The following is a description of a gene set: Any process that modulates the frequency, rate or extent of polyamine transmembrane transport. Mouse Gene Set: GOBP_REGULATION_OF_POLYAMINE_TRANSMEMBRANE_TRANSPORT species: Mus musculus, and this is the list of marker genes: Oaz3, Oaz1, Ldc1, Azin2, Oaz2, Azin1